Given this list of marker genes MORF4L1, DMAP1, ACTR2, TRRAP, RAD51AP1, HDGFL2, MBTD1, RNF8 (NCBI Gene Id 9025), ING3, OOEP, ARID2, MEAF6, YEATS4, RUVBL1, WAS, CREBBP, RUVBL2, KHDC3L, FANCB, SKP2, MRGBP, KAT5, NBN, ACTL6A, WDR48, EPC1, PARP1, RNF126, MRNIP, VPS72, EPC2, TIMELESS, FUS, WRAP53, PELI1, PIAS4 (NCBI Gene Id 51675), MORF4L2, ERCC6, ACTB, HELQ, BRD8, EP400, PRMT1, here is a description of the gene set: studied in species Homo sapiens Human Gene Set: GOBP_POSITIVE_REGULATION_OF_DOUBLE_STRAND_BREAK_REPAIR_VIA_HOMOLOGOUS_RECOMBINATION Any process that activates or increases the frequency, rate or extent of double-strand break repair via homologous recombination.